Given this list of marker genes FGFR1, ERLIN2, BAG4, here is a description of the gene set: In addition to the cytosolic FGFR1 fusions identified in 8 myeloproliferative syndrome, plasma membrane localized FGFR1 fusions have been identified in glioblastoma, breast cancer and non small cell lung cancers. A FGFR1:TACC1 fusion identified in glioblastoma promotes anchorage independent growth when expressed in Rat1A cells, while an ERLIN2:FGFR1 fusion in breast cancer shows constitutive autophosphorylation when expressed in HEK 293 cells. All FGFR1 fusions tested also shown increased sensitivity to growth inhibition upon treatment with kinase inhibitors. species: Homo sapiens part of: FGFR1 mutant receptor activation Reactome Pathway: Signaling by plasma membrane FGFR1 fusions